The following is a description of a gene set: Distance between the hairline (trichion) and the glabella (the most prominent point on the frontal bone above the root of the nose), in the midline, more than two SD below the mean. Alternatively, an apparently decreased distance between the hairline and the glabella. species: Homo sapiens Human Gene Set: HP_LOW_ANTERIOR_HAIRLINE Low anterior hairline, and this is the list of marker genes: COG7, VPS13B, SMARCC2, CREBBP, PPP1R15B, SOX11, RPS10, RPS20, FOS, RPL31, LIG4 (NCBI Gene Id 3981), TRMT10A, RPS17, ZFX, RPL9, SLC12A6, TWIST2, DPF2, FREM2, RAB3GAP2, SMARCD1, TSR2, RPL27, CDK5, RPL5, SMC3, EMC1, BRCA1, RBL2, NUDT2, FGFR3, PRDM13, H3-3A, TCF12 (NCBI Gene Id 6938), HSPG2 (NCBI Gene Id 7796), SMARCB1, RPL35A, POLR1D, ZNF699, ASH1L, RPS27 (NCBI Gene Id 6232), RPL15, SMPD4, TAF6, TWIST1, PIK3C2A, MEGF8, BICRA, PACS1, SLC35C1 (solute carrier family 35 member C1), SH2B1, HEATR3, TMCO1, RPL35, RPL11, SLC25A24, TBC1D20, RPS19, MED13L, TBX2, BSCL2, ABCC9, NOTCH2, XRCC4, NIPBL, EP300, CNTNAP2, LRPPRC, GATA1, PPARG, RHOBTB2, KREMEN1, MAN2B1, MAPRE2, CAVIN1, ZIC1, TBX15, TCOF1, UBAP2L, NANS, SMARCE1, ARID2, H4C5, SPEN, FKRP, STAG2, RPS28, SPOP, DPM2, TRIO, AIFM1, HDAC8 (histone deacetylase 8), CIT, AGPAT2, ATP6V1B2, RPS29, MAB21L1, PGAP1 (NCBI Gene Id 80055), ALG11, SMARCA4, FILIP1, ARID1A, RPS26, TRPM3, RALGAPA1, NBN, TTC5, PEPD, FGFR2, MAP3K7 (NCBI Gene Id 6885), SETD5, VPS33A, AFG2B, RPL18, RAD21 (RAD21 cohesin complex component), CDC42BPB, POLR1C, IGF1, RPL8, RAB18, ERI1, ARID1B, ERMARD, RPS15A, POLR1B, ASXL1, SVBP, KCNH1, CAV1, NSUN2, SMC1A, DOCK6, ADA2, SMARCA2, RPL26, KCNN3, TBC1D24, FRMD4A, CAPRIN1, TECPR2, DOCK7, RPS24, KCNJ8, BRD4, SOX4, RPS7, ANKRD11, CLCN3, INSR, ARX